Given this list of marker genes Sox6, Ruvbl1, Gsk3b, Cav1, Frat1, Uba52rt, Ryk, Bcl9, Tnks, Rspo4, Ep300, Ubc, Ppp2r1a, Sost, Psmd12, Men1, Akt1, Psma7, Psmc6, Tle2, Hecw1, Psma3, Rbbp5, Psma5, Psma4, Psmc4, Ppp2ca, Dact1, Fzd1, Psma2, Pygo2, Ubb, Psmb7, Adrm1, Bcl9l, Igfals, Ash2l (NCBI Gene Id 23808), Trrap, Kat5, Fzd5, Psmd1, Smurf2, Sox9, Amer1, Psmd8, Leo1, Cul3, Csnk1a1, Wnt3, Dkk1, Psmd13 (proteasome (prosome, macropain) 26S subunit, non-ATPase, 13), Lrp5, Ctnnb1 (catenin beta 1), Tcf7l2, Fzd2, Cdc73, Usp8, Csnk2b, Psmd3 (proteasome (prosome, macropain) 26S subunit, non-ATPase, 3), Kremen2, Psma6, Klhl12, Xpo1, Rnf43, Ppp2r5d, Psmb1, Sox17, Dvl2, Wnt8b, Fzd4, Psmd11, Pip5k1b, Csnk2a1, Tle1, Psmb4, Sox7, Psmc3, Kmt2d, Akt2, Psmd2, Tert, Psmb5, Kremen1, Cby1, Wnt3a, Smarca4, Tnks2, Rbx1, Dkk4, Rspo2, Tcf7 (NCBI Gene Id 21414), Chd8, Znrf3, Psmc2, Sox13, Fzd6, Ctbp1, Ppp2cb, Lrp6, Sox4, Hdac1, Ywhaz, Ppp2r5b, Dvl3, Psma1, Psmd14, Psmc5, Xiap, Csnk1e, Dvl1, Csnk2a2, Psmd6, Tle4, Pygo1, Fzd8, Lgr5, Lef1 (lymphoid enhancer binding factor 1), Sox3 (SRY (sex determining region Y)-box 3), Wnt5a, Wnt8a, Tcf7l1, Psmb6, Ppp2r5a (protein phosphatase 2, regulatory subunit B', alpha), Frat2, Rspo1, Rspo3 (NCBI Gene Id 72780), Ppp2r5e, Psmc1, Dkk2, Ctnnbip1, Psmb2, Ppp2r1b, Rnf146, Psmd7, Uba52, Rps27a, Tle3, Apc, Usp34, Axin2, Psmb3, Axin1, Ppp2r5c, Wnt1, here is a description of the gene set: TCF dependent signaling in response to WNT species: Mus musculus Mouse Gene Set: REACTOME_TCF_DEPENDENT_SIGNALING_IN_RESPONSE_TO_WNT